The following is a description of a gene set: Brushfield spots Human Gene Set: HP_BRUSHFIELD_SPOTS The presence of whitish spots in a ring-like arrangement at the periphery of the iris. species: Homo sapiens, and this is the list of marker genes: PEX16, PEX5, PEX6, PEX1, PRR12, PEX14, PEX26 (NCBI Gene Id 55670), PEX13, PEX2, PEX12, PEX11B, PEX19, PEX3, PEX10